The following is a description of a gene set: studied in species Mus musculus The lipid bilayer surrounding any membrane-bounded vesicle in the cell. Mouse Gene Set: GOCC_VESICLE_MEMBRANE, and this is the list of marker genes: Ece2, Rab15, H2-D1, Gabrg2, Ica1, Mical1, Vps28, Abcb6, Sun1, Otof, Cfap65 (cilia and flagella associated protein 65), Oca2, Itch, Rac1, Epn2, Vps4a, Gimap5 (NCBI Gene Id 319541), Tom1l1, Nrgn, Snf8, Slc17a9, Vps29, Rab13, Abcc4 (NCBI Gene Id 239273), Ncdn, Aqp2, Steap1, Sec31b, Vamp2, Agtrap, Sec16b, Pld3, Rab10, Abca13, Vps26a, Clec16a, Slc17a8, Dbnl, Ocrl, Abhd17b, Clip1, Vps25 (NCBI Gene Id 68583), Tmem63a, Tyrp1, Bsg, Pam, Snx16, Rabepk, Marchf2, H2-Ob, Lin7c, Ticam1, Mkln1, Gria1, Vps37a, Rab34, Dbh (dopamine beta hydroxylase), Grin2b, Gabarapl1, Rab23, Marchf11, Zp3r, Ace3, Ticam2, Sppl2a, Enthd1, Rapgef1, H2-M10.1, Aqp1, Aftph, Slc26a6, Commd1, Cubn, H2-Ea, Rab39, Pikfyve, Tyr, Grb2, Atp6v0c, Entrep1, Ret, Lamtor4, Pigr, Slc6a7, Traf3, Tmem59, Mcoln2 (NCBI Gene Id 99673), Zpbp, Pi4k2b, Neu3, Anxa11, Mcoln3, D130043K22Rik, Entpd7, Sv2b, H2-Q1, Snx6, Rassf9, Adam8, Stx12, Tfrc, Gbp5, Syngr4, Tmem9, Atp6v0d1, Sec24a, Unc13c, Atp10b, Atp6v1a, Cd300lg, Ulk1, Rab32, Tlr8, Sar1a, Snca, Gpr89, Abca12, Stx8, Washc3, Laptm4a (lysosomal-associated protein transmembrane 4A), Hyal5, Cav2, Vps33a, Calm2, Sh3gl3, Treml4, Dcst2, Zmpste24, Spaca1, Amph, Rab11fip1, Rph3al, Atp6v1c1, Clcn6, Atp6v1g2, Grin1, Abca7, Gad1, Ephb1, Sec13, Ctns, Rph3a, H2-Q7, Syt1, Gper1, Slc2a3, Ehd3, Pacsin2, Slc36a2, Lrrk2, Parm1, Fzd6, Sec23a, Copz2, Atp6v1e1, Itpr3, Anxa8, Stx16, H2-M11, Arhgap32, Atp13a2, Caly, Clint1, Yipf1, Plekhb2, Sec23ip, Slc30a8, Hps6, Dnm2, Tmem106b, Borcs5, Scarb2, Tmem184a (NCBI Gene Id 231832), Dnm1l, Cd1d2, Bcl2l1, Rab5b, Atg9a, Tex101, Tpcn1, Rnft1, Lrig3, Plekhf2, Ap2m1, Bace1, Rab5c, Ubxn6, Chmp1b2, Calm1, Llgl1, Slc9a4, Iyd, Pef1, Slc32a1, Atp8b5, Abca2, Scgn, Snx14, Kir3dl1, Cpe, Ptprs, Laptm4b, Gripap1, Cspg5, Mreg, Tbc1d5, Atp11c, Slc17a6, Flrt1, Zdhhc17, Atp6v0e2, Nmnat2, Washc2, H2-M2, Nck2, Sv2c, Vps11, Syt6, Tsg101, Notch1, Snx18, Ehd2, Scara5, Wdr81, Atp6v1h, Slc26a7, Whamm, Rab8a, Aqp11, Fcmr, Camkv, Rab31, Sh3gl2, Sec24d, Slc15a3, Snx17, Clic4, Ptprn2, Tasl, Tmem95, Slc28a2b, Galntl5, Slc22a2, Snap91, Slc30a10, Tnk2, Copa, Dcst1, Gde1, Ap1g1, Vps45, Slc2a4, Pip5k1c, Vps16, Zdhhc13, Saysd1 (NCBI Gene Id 74979), Ccdc136, Srebf2, Ap1g2, Syt7, Dab2, Egfr, Copb1, Unc13b, Cd177, Snx20, Scap, Sh3bp5, Vps37c, Zfyve27, Cd68, Scg3, Trpm7 (transient receptor potential cation channel, subfamily M, member 7), Stard3, Pmepa1, Gga2, Rab4b (RAB4B, member RAS oncogene family), Acap1, Rab2a, Atp6ap1, Snx12, Ppt1, Tafa4, Reep6, Stard3nl, Rab38, Wfs1, Slc35g2, Dio3, Zg16, Tap1, Igtp, Inpp4a, Cbarp, Malrd1, Copg1, Plekhm2 (NCBI Gene Id 69582), H2-M10.6, Washc4, Plpp2, Rap2c, Wipi1, Bok, Vti1b, Cope, Dlg1, Vamp8, Tlr9, Vps18, Snx5, Was, Scamp5, H2-M10.2, Vamp4, Lztr1, Chmp1a, Ndrg1, Cav1, H2-M5, Slc5a7, Sytl2, Epn3, Sec16a, Arhgap26, Mmgt2, Atp2b1, Gga1, Slc9a3, Aspscr1, Snx30, Stam2, Moxd2, Gpr135, Tlr3, Gabra2, Slc9a7, H2-Q2, Snx1, Abcg4, Gabra1, Appl1, Abhd17a, Hyal3 (NCBI Gene Id 235600), Shc1, Snx33, Aqp4, Sorcs2, Abhd2, Golga5, Myo6, Mvb12b, H2-T22, Vps4b, Snx13, Clca1, Aqp6, Sort1, Dennd4c, Tepsin, Rab11a, Scnn1b, Spire2, Ifitm2, Syt2, Map6, Rap2a, Dcstamp, Slc9a6, Ap2s1, Mpeg1, Rmc1, Phaf1, Pfpl, Necap1, Cd63, Cplx3, Car4, Cylc1, Rab3a, Clcn4, Vps13c, Dync1li1, Rab27b, Washc5, Slc35d3, Ston2, Baiap2l2, Dtx3l, Leprot, Syt12 (synaptotagmin XII, NCBI Gene Id 171180), Litaf, Cemip, Pdlim4, Syt10, Sycn, Svop, Lamp2, Pld1, Tor1a, Dct, Izumo3, Tmem225, Anxa6, Osbpl9, Snapin, Tmem199, Arcn1, Elapor1, Fmn2, Atp6v0b, Anxa5, Syt3, Ap2a1, Anxa1 (annexin A1), Ap4b1, Clta, Vps52, Acap2, Rab43, Snx4, B2m, Syt5, Uso1, Kir3dl2, Hsd17b6, Snx21 (NCBI Gene Id 70479), Vps13b, C2cd5, Usp8, Chmp4b, Sbf2, Sec24c, Ncstn, Furin, Ankrd27, Atp8a1 (ATPase phospholipid transporting 8A1), Eqtn, Flot2, Gpr61, Sri, Syt13, Inpp5b (inositol polyphosphate-5-phosphatase B), Arpc2, Slc39a4, Eef1ece2, Clvs2, Abhd17c, Ap3s2, Syp, Gpnmb, Arhgap10 (Rho GTPase activating protein 10), Ap3d1, Rab8b, Traf2, Sypl1, Rab39b, Kif1a, Vps13a, Fndc3a, Grin2a, Ldlr (low density lipoprotein receptor), Gbp2, Tmem163, Prrt2 (proline-rich transmembrane protein 2), Snx27, Kcnh1, Dmbt1, Htr4, Pkdrej, Pcsk4, Cln3, Chmp3, Dgki, Irgm2, Rab4a, Phf24, Myo1c, Pde6d, Syt9, Cdip1, Abca4, Arfgef3, Anxa9, Gpr151, Rab3b, Wls, Kif16b, Mfge8, Ykt6, Tom1, Snx15, Hip1r, Rab9, Coro1a, Pla1a, Amn, Ap3s1, H2-M10.4, Sec61a1, Sec31a, Chmp2b, Vamp5, Lamtor3, Ap3m2, Ap5m1, Kifc3, Pnliprp2, Atp6v1g3, Rep15, Clec4e, Slc6a9, Slc18a3, Slc11a2, Zdhhc11 (NCBI Gene Id 71164), Pml, Cftr, Pip4p2, Praf2, Cc2d1b, Rab11fip4, Tmem67, Sparc, Ifitm7, Trip11, Ube2d3, Syngr2, Rnasek, Vopp1, Slc9a5, Adcy8, Sppl2b, Npc1, Dnajc13, Spire1, Chmp1b, Zpld1, Canx, Ldlrad4, Kdelr1, Atp6v1f, Snx2, Trf, Appbp2, Ntrk2, Pdcd6, Slc30a1, Fzd7, Zfyve16, Rffl, Rab9b, Oprk1, Izumo1, Slc4a11, Syn1, Ap1s1, Osbpl6, Slc1a1, Yipf2, Epn1, Plin3, Lamtor1, Znrf2, Nsg2, Mmgt1, Exoc3, Spaca6, Atp9a, Ap5s1, Synpr, Pi4k2a, Rnf167, Creb3l4, Mff, Tlr6, Mrc1, Gipc1, Atp6ap2, Stxbp2, Chmp2a, Tmed2, Tmed3, Tcirg1 (NCBI Gene Id 27060), Mcoln1, Atm, Fgd2, Rab6a (RAB6A, member RAS oncogene family), Tprg1l, Vps53, Vamp3, Fcgrt, Anxa4, Chmp5, Slc30a2, Sting1, Dmxl2, Slc38a9, Cc2d1a, Stx17, Smo, Slc2a8, Osbpl11, Vps41, Mtmr4, Snx24, Clcn5, Sntb2, Slc9a8, Zdhhc1, Hgs, Slc6a17, Rab14, Syt8, Slc39a13, Moxd1, Sphk1, Rab11fip5, Rab11fip3, Ntrk1, Prrt1, Sv2a, Gpr18, Erbb2, Rab3c, Clcn3, Dennd1a, H2-Oa, Trpm2, Mctp2, Drd2, Scamp3, H2-Aa, Arhgap21, Uba1, Cltc, Ap3b2, Epha8, Ap3m1, Plekhm1, Ap1b1, Dagla, Arhgap1, Slc46a2, H2-Ab1, Septin8, Sppl2c, Litafd, Dlg2, Bace2, Sypl2, Micall1, Pi4ka, Arc, Steap4, Cptp, Anxa13, Eps15, Steap2, Vps37b, Lamp1, H2-T23, Slc30a5, Slc30a4, Anp32e, Atp6v0a2 (ATPase, H+ transporting, lysosomal V0 subunit A2), Ankfy1, Slc11a1, Selp, Arl8a, Snap29, Gbp7, Ehd1, Sgsm1, Kdelr2, Slc12a2, Ncf4, Stoml1, Baiap3, Fam170b, H2-K1, Apc, Tmem190, Mctp1, Pla2g4b, Tmed10, Spaca4, Rab20 (NCBI Gene Id 52122), Kcnj4, Clvs1, Dse, Gpr143, Cd1d1, Doc2a, Mvb12a, Slc46a1, Abca3, Syn2, Rab26, Cyb561a3, Slc18b1, Mr1, Zdhhc2, Sec24b, Rhov, Cyb561d2, Snx9, Glipr1l1, Slc9a9, Atp13a3, Atp6v1g1, Tmem165, Gga3, Tmem45b, Lamtor5, Vps33b, Cadps, Cd274, Nsg1, Rab21, Zfyve28, Ap3b1 (NCBI Gene Id 97864), Aqp5, Cmtm6, Becn1 (NCBI Gene Id 56208), Chmp4c, Tlr2, Rbsn (rabenosyn, RAB effector), Sorl1 (sortilin-related receptor, LDLR class A repeats-containing), Serpina5, Slc39a14, Ap1m2, Pmel, Vamp1, Spred2, Slc6a2, H2-DMb1, Dop1b, Atp7a, Pkd2, Kif1b, Mmd, Rufy1, Rab17, Snx10, Itpr1, Gabrb3 (GABRB3, gamma-aminobutyric acid type A receptor subunit beta 3), Gpr62, Rcc2, Myo5b, Rala, Ubap1l, Tab2, Abca5, Dgkq, Aqp7, Chmp6, Itpr2, Kif13a, Cyb561, Tmem63b, Copb2, Mtmr2, Tlr7, Snx3, Rnf144a, Th, H2-Eb1, Sema4c, Chmp7, Slc15a4, Gad2, Marchf8, Slc48a1, Itm2b, Btbd8, Tm9sf2, Stx3, Synrg (synergin, gamma), Myof, Golim4, Vac14, Slc10a4, Atp6v1b1, Rab7b, Trim72, Slc35f1, Srebf1, Spns2, Tapbp, Clip3, Syngr3, Ift88, Rilp, Rab5a, Napepld, Tbc1d4, Kcnq1, Mapkap1, Dipk2a, Tmem9b, Tmem175, Atg9b, Vta1, Atp13a4, Tpcn2, H2-Q10, Slc30a3, Atp8b3 (ATPase, class I, type 8B, member 3), Disp3, Cd164, Acrbp, Sgip1, Abcc5, Vti1a, Arl8b, Insr, Marchf1, Oprd1, Slc18a1, Tlr13, Lin7b, Sh3kbp1, Rab7, Rap2b, Sec22b, Kdelr3, Ffar4, Syndig1, Numb, Anxa2, Mfsd12, Scamp4, Gbp2b, Vps35, Vma21, Zfyve9, Slc4a8, Ptprn, Taok2, Scamp1, Atp6v1b2 (NCBI Gene Id 97492), Dysf, Anxa10, Sppl3, Ap1s3, Cltb, Tmem30a, Snx25, Snx8, Csf3r, Prkn (parkin RBR E3 ubiquitin protein ligase), Spata31, Slc28a2, Atg16l1, Syngr1, Slc18a2, Spaca3, Epha4, Rab11fip2, Mfsd8, Appl2, Sgta, Stam, Copz1, Abcb11, Atp8a2, Atp6v1d, Stx7, Or51e2, Atr, Scyl1, Sytl4, Igf2r, Hvcn1, Ulk2, Dmd, Vps37d, Mitd1, Ifitm3, Syn3, Gm12250, Arf6, Smagp, Cuzd1 (CUB and zona pellucida-like domains 1), Rnd2, Tmem108, Eea1, Rhob (NCBI Gene Id 11852), Irgm1, Pla2g4e, Mfsd10, Sar1b, Lin7a (lin-7 homolog A, crumbs cell polarity complex component), Stx1a, Rnf13, Vps36, Pacsin1, Sec23b, Uevld, Acp3, Klhl12, Sun2, Gprc5b, Tmem150b, Dtnbp1, Lamp3, Ap1s2, Anxa7, Akap5, Htt, H2-DMa, Slc26a9, Abcc8, Slc15a2, Tekt3, Tbc1d24, Slc9b2, Copg2, Atp6v0a4, Calm3, Diaph3, Cd46, H2-Eb2, Ap2b1, Cadps2, Unc13a, H2-DMb2 (histocompatibility 2, class II, locus Mb2), Stx6, H2-T3, Coro1c, Sh3gl1, Anxa3, Znrf1, Slc31a1, Scamp2, Psen1, Wdr44, Stxbp5, Rab35, Clba1, Ap2a2, Mal2, Gosr2, Snx7, Ap1m1 (NCBI Gene Id 11767), Lamtor2, Rab27a, Ston1, Slc31a2, Hip1, Fig4 (FIG4 phosphoinositide 5-phosphatase), Actn1, Slc6a4, Atp6v0a1, Syt4, Spaar, Nck1, Slc17a7, Gp2, Synj1, Tspan15 (NCBI Gene Id 70423), Vps39, Atp11b, Syt11, Doc2b, Ubap1, Washc1 (NCBI Gene Id 68767), Ndfip1, Ehd4, Grb14, Tmbim1, Marchf3, Slc17a5, Thsd1, Rab11b, Cideb, Slc29a3, Tlr4, Steap3, Wdr91, Gria2, Tlr1, Slc45a2, Bin1, Abhd6, Mon2, Dll3, Lnpep, Rab12, Trarg1, Dnajc5, Myo1b (NCBI Gene Id 98177), Necap2, Atp13a5, Gnpnat1, Rab22a, Pip4p1, H2-Q6, Ctsd, Scyl2, Lamp5